The following is a description of a gene set: Binding to a vascular endothelial growth factor receptor. studied in species Homo sapiens Human Gene Set: GOMF_VASCULAR_ENDOTHELIAL_GROWTH_FACTOR_RECEPTOR_BINDING, and this is the list of marker genes: VEGFC, GREM1, CADM4, VEGFA, VEGFD (NCBI Gene Id 2277), PDCL3, PGF, ITGB3 (integrin subunit beta 3), ITGA5, DAB2IP (NCBI Gene Id 84635), CCDC88A, CDH5, VEGFB